Given this list of marker genes S100A10, RGCC, FOS, NFKBIZ, EGLN3, NR4A1, NR4A2, NAB1, HMGCS1, SOWAHC, PTGER4, here is a description of the gene set: species: Homo sapiens from publication Pedersen K, Angelini PD, Laos S, Bach-Faig A, Cunningham MP, Ferrer-Ramón C, Luque-García A, García-Castillo J, Parra-Palau JL, Scaltriti M, Ramón y Cajal S, Baselga J, Arribas J (PMID 19364815) Human Gene Set: PEDERSEN_METASTASIS_BY_ERBB2_ISOFORM_5 Genes regulated in MCF7 cells (breast cancer) by expression of the truncated (611-CTF) form of ERBB2 at 15 h time point. HER2 is a tyrosine kinase receptor causally involved in cancer. A subgroup of breast cancer patients with particularly poor clinical outcomes expresses a heterogeneous collection of HER2 carboxy-terminal fragments (CTFs). However, since the CTFs lack the extracellular domain that drives dimerization and subsequent activation of full-length HER2, they are in principle expected to be inactive. Here we show that at low expression levels one of these fragments, 611-CTF, activated multiple signaling pathways because of its unanticipated ability to constitutively homodimerize. A transcriptomic analysis revealed that 611-CTF specifically controlled the expression of genes that we found to be correlated with poor prognosis in breast cancer. Among the 611-CTF-regulated genes were several that have previously been linked to metastasis, including those for MET, EPHA2, matrix metalloproteinase 1, interleukin 11, angiopoietin-like 4, and different integrins. It is thought that transgenic mice overexpressing HER2 in the mammary glands develop tumors only after acquisition of activating mutations in the transgene. In contrast, we show that expression of 611-CTF led to development of aggressive and invasive mammary tumors without the need for mutations. These results demonstrate that 611-CTF is a potent oncogene capable of promoting mammary tumor progression and metastasis.